Given this list of marker genes LAMB2, COL3A1, LAMC1, LAMA1, COL7A1, COL4A4, here is a description of the gene set: We have previously developed methods for enriching tissue samples for their ECM protein content by taking advantage of the relative insolubility of the ECM, and we have used these techniques in conjunction with mass spectrometry-based proteomics to profile the matrisome, the complete collection of both core ECM and ECM-associated proteins, in several different cancers. Here we define and compare the ECM components of metastatic niches and how they differ among the specific secondary sites common in TNBC. For this purpose, we use as a model the MDA-MB-231 human TNBC cell line, originally derived from a patient pleural effusion (24), which is capable of metastasizing to the brain, lungs, liver and bone marrow in mouse xenografts. We identify which ECM proteins are commonly elevated at multiple different metastatic sites, and which are preferentially elevated in particular sites. We investigate how these specific ECM proteins, as well as the tumor matrix overall, are differentially produced by the tumor and stromal cells; in this paper, we use stromal to include all cells in the tumor that are not tumor cells. These comparisons did not simply identify the most elevated proteins in each tissue, but rather the proteins most significantly different in abundance in one tissue relative to all others. Separate analyses were conducted for tumor-cell-derived (human) and stroma-derived (mouse) proteins. In this study, we performed an unbiased, quantitative mass spectrometric survey of ECM proteins present in MDA-MB-231 breast cancer xenograft metastases to the brain, lungs, liver and bone marrow. This gene set lists the tumor-cell secreted matrisome proteins found in significantly higher abundance in TNBC lung metastasis niche compared to TNBC brain, liver and bone metastatic niches. Human Gene Set: HEBERT_MATRISOME_TNBC_LUNG_METASTASIS_TUMOR_CELL_DERIVED studied in species Homo sapiens Tumor cell-derived matrisome proteins found in significantly higher abundance in TNBC lung metastasis niche compared to TNBC brain, liver and bone metastatic niches. from publication Hebert JD, Myers SA, Naba A, Abbruzzese G, Lamar JM, Carr SA, Hynes RO (PMID 32019869)